The following is a description of a gene set: species: Homo sapiens from publication Dienz O, Eaton SM, Bond JP, Neveu W, Moquin D, Noubade R, Briso EM, Charland C, Leonard WJ, Ciliberto G, Teuscher C, Haynes L, Rincon M (PMID 19139170) Human Gene Set: GSE7459_UNTREATED_VS_IL6_TREATED_ACT_CD4_TCELL_UP IL-6, a proinflammtory cytokine produced by antigen presenting cells and non-hematopoietic cells in response to external stimuli, acts as an important bridge between the innate and adaptive immune responses. IL-6 together with IL-4 can promote Th2 polarization, while in combination with TGFbeta mediates Th17 differentiation. We examined early changes in gene expression in mouse CD4+ T cells induced by IL-6. Genes up-regulated in CD4 T cells: control versus IL6., and this is the list of marker genes: KDM4B, COL11A1, PDE7A, CACNB3, RBAK, NELFA, CRLF3, LEF1, COMP, P2RX2, ZNF394, ABI3BP, CBFA2T2, PNMA5, PPP3CC, ORAI2, GRAMD2A, SCLY, WDFY1, LIN7C, MIR7-2, NLRP6, BRD7, FAM169BP, PTGR3, MIR151A, NUDCD3, SPATA2, CCDC33, G3BP2, MTHFD2L, ALPK2, TBXA2R, NDRG3, DHX16 (NCBI Gene Id 8449), IL17RA, ELMOD1, AGFG1, ACTL7B, CPA1, UPRT, RFPL4B, ANKRD60, SRPRA, CNNM2, SLC20A1, EFR3A, SPATA9, ROBO3, GPR101, ZIC3, PPM1K, MRAP2, SGTB, GALC, DYNLT5 (NCBI Gene Id 200132), NR6A1, ESRP2, CDHR5, PIK3R4, PGAP1, MMP16, CTNS, KCNV1, SNAPC4, STAP1, YTHDC2, UGGT1, PLCXD2, ATP6V0A2, SLC30A8, IL1RAP, EFCAB6, EHMT1 (euchromatic histone lysine methyltransferase 1), CNN1, PPP4R2, SEC61A2, TOR3A, DDX23, CDKL3, RASGRP2, HDX, DOLK, DDX52, PLEKHA5, GRIPAP1, FOXN3, MAPK6, PIK3IP1, FOXD3, ABLIM3, DDHD1, RNF145, MIRLET7B, EML5, GIMAP7, PLEKHM1, CFAP100, HCFC1, VAV1, EML1, RNF123, GABPA, ECEL1, RFNG (RFNG O-fucosylpeptide 3-beta-N-acetylglucosaminyltransferase), CLDN19, STAT3, NF1, GFPT1, AMPD1, ANAPC1, ZC3H12D, HNF1A (NCBI Gene Id 6927), MORC4, MARCHF6, CYP2E1, TBX20, CCDC70, OPN1MW, KIF2B, FFAR1, MTFMT, ZBTB49, LSAMP, RANBP10, TTC5, SLC23A2, CLEC1B, SMAD5, ASB13, CAPZA3, GLRB, ZDHHC17, USP28 (NCBI Gene Id 57646), RASD2, DDX5, MIR137, SLC22A6